The following is a description of a gene set: We have analyzed the developmental molecular programs of the mouse hippocampus, a cortical structure critical for learning and memory, by means of large-scale DNA microarray techniques. Of genes and expressed sequence tags examined, 1,926 showed dynamic changes during hippocampal development from embryonic day 16 to postnatal day 30. Gene-cluster analysis was used to group these genes into 16 distinct clusters with striking patterns that appear to correlate with major developmental hallmarks and cellular events. These include genes involved in neuronal proliferation, differentiation, and synapse formation. A complete list of the transcriptional changes has been compiled into a comprehensive gene profile database (http://BrainGenomics.Princeton.edu), which should prove valuable in advancing our understanding of the molecular and genetic programs underlying both the development and the functions of the mammalian brain. Genes up-regulated in hyppocampus at late postnatal stages (clusters 11 and 15). species: Mus musculus Human Gene Set: MODY_HIPPOCAMPUS_POSTNATAL from publication Mody M, Cao Y, Cui Z, Tay KY, Shyong A, Shimizu E, Pham K, Schultz P, Welsh D, Tsien JZ (PMID 11438693), and this is the list of marker genes: SYT1, NAPA, LDHB, PYGM, GRIA1 (NCBI Gene Id 2890), SDHA, BDNF (NCBI Gene Id 627), SOX10, EGR1, EEF1A2, SH3GL2 (NCBI Gene Id 6456), COX8A, RHOB, GRIA2, MAPK3, DGKZ, VAMP2, CLTB, APBB1, PRDX6, ATP6V1B2, NPTX1, PPP3CA, FBXW7, BIN1, RASGRF1, PKM, MDH1, KCNMA1, RYR2, VDAC1, GPD1, GK, NTSR2, ATP2A2, NDUFB2, HRAS, ENO2, NRGN, CCK, KCNAB1, PTK2B, PFKL, AIP, ATP6V1E1, STXBP1, GRINA (NCBI Gene Id 2907), ALDOA, SIRT3, ARHGEF25, ATP6AP1, NDUFS2, ATP6V1C1, TPI1, CX3CL1, TYRO3